Given this list of marker genes Cd274, Hfe, Zbtb7b, Socs1, Dapl1, Slc4a2, Vsir, here is a description of the gene set: Mouse Gene Set: GOBP_NEGATIVE_REGULATION_OF_CD8_POSITIVE_ALPHA_BETA_T_CELL_ACTIVATION Any process that stops, prevents or reduces the frequency, rate or extent of CD8-positive, alpha-beta T cell activation. species: Mus musculus